The following is a description of a gene set: Binding to flavin mono nucleotide. Flavin mono nucleotide (FMN) is the coenzyme or the prosthetic group of various flavoprotein oxidoreductase enzymes. species: Mus musculus Mouse Gene Set: GOMF_FMN_BINDING, and this is the list of marker genes: Mtrr, Ndufv1, Tyw1, Dus2, Hao1, Dhodh, Ppcdc, Nos2, Por, Iyd, Ndor1, Nos3, Hao2, Nos1, Pnpo